Given this list of marker genes Myo7b, Myl9, Myo3a, Myo9a, Myo5a, Myh13, Myo6, Myo1b, Myl6, Myh15, Mlph, Myo1g, Myo5b, Myh2, Myh6, Myo10, Myo1c, Myo1d, Myl7, Myo1f, Myo1h, Myh11, Myh7b, Ccdc102a, Myo1e, Mylpf, Myl4, Myl6b, Myh10, Myo19, Bmf, Myh3, Myl3, Ttn, Myh14, Myo16, Myh4, Cgnl1, Limch1, Myo9b (NCBI Gene Id 17925), Myh9, Myo7a, Cgn, Dynll2, Myl2, Myl12b, Myh8, Myo18a, Myh1, Myo3b, Myo15a, Myo1a, Myl1, Myl12a, Myo18b, Myh7, here is a description of the gene set: A protein complex, formed of one or more myosin heavy chains plus associated light chains and other proteins, that functions as a molecular motor; uses the energy of ATP hydrolysis to move actin filaments or to move vesicles or other cargo on fixed actin filaments; has magnesium-ATPase activity and binds actin. Myosin classes are distinguished based on sequence features of the motor, or head, domain, but also have distinct tail regions that are believed to bind specific cargoes. Mouse Gene Set: GOCC_MYOSIN_COMPLEX species: Mus musculus